Given this list of marker genes ECI2, UQCC5, PGM2L1, EXOC4, CS, TJP3 (tight junction protein 3), CXCL14, NIPAL3, SH3BGRL2, UBTD1, DDX3X, BAG6, KBTBD13, MICOS10, TBC1D15, CCDC22, APRT, CLUH, DENND4C, FLNA, SPEN-AS1, ATXN1, TRUB2, PIK3R2, ABHD12, TOMM6, CAMK1, IFI27, GTF2I, LGALS4, COL4A2, TGFBR1, MRPL20, CTNNB1, SH2B1, SERPINB6 (serpin family B member 6), GIT1, MT1E, HEBP1, ATP5MG (ATP synthase membrane subunit g), RALGDS, SSBP4, PABPC4, AGFG2 (NCBI Gene Id 3268), HADHA, DENND4B, MTURN, EEPD1, CCT3, DOCK5, SH3PXD2A, KLHL9, MGST1, GGA1, RAPH1, BOLA2, SPNS1, CAV1, PSEN2, SULT1A1, ST13, AGPAT5, ALDH16A1, LDHB, TMBIM1, IPO4, ITGB3, DDX19A, CNKSR3, MRPS6, PCDHGC4, RXRA, LRRC39, SDC1, AIFM2, NDUFA6, ZNF560, FAM209A, HBP1, PMM1, NDFIP1, SAMD4A, FCGRT, LRP1, NADK, MRPL23, SLC12A7, PEX5, STAB2, SOX7, GPCPD1, ITGAV, SLC11A1, MAN2B2, KDELR1, HSD17B4, MMGT1, FAM83F, SCARB2, MERTK, AGPAT1, MYO18A, ANO6, ANAPC13, ATP11C, ACBD5, PLIN2, MGLL, DMXL2, ADAM22, GLIS3, RAMP1, TRAPPC1, ACTN1, SKIC8, ENPP1, DAD1, RIT1, GPX4 (NCBI Gene Id 2879), GNA12, SLCO2B1, ZC3H3, ABCG1, CAT, GLRX5, RNF166 (NCBI Gene Id 115992), ALDH9A1, USP34, SNX9, PGLS (NCBI Gene Id 25796), TMEM208, OSGIN1, PRKAR2A, FBXL19, TPRA1, NPC1, CCNQ, TBCC, ICAM4, CD82, PRXL2A, TRAPPC10, SYK, HNMT, EEF2, SORD, SEPTIN9, GGA2, SPHK2, LAMTOR4, PLXDC2, BLVRB, DGLUCY, ABHD3, ATP13A3, SCAMP3, MFSD14A, HADHB, ZNF706, MRPS33, SELENOP, OAZ1, GCLM, PPT2, RAB29 (RAB29, member RAS oncogene family), ISCU, NEURL2, PDGFC, ARHGAP18, VAPA, ETFB, HVCN1, ANGPTL3, TMEM245 (NCBI Gene Id 23731), TAF1D, CLCN4, ECH1, ST18, SEPHS2, ZFAND2B, MAPRE1, CDK5R1, NME2, HNRNPL, KIF1C, NATD1, ACAA2, TKT, PNRC1, GNGT2, IMP3, HGSNAT, CD300A, TRAPPC6A, CCDC47, AFF4, ASPA, IQSEC1, SH3BGRL3, TBC1D2, here is a description of the gene set: IL-10 or IL-6 stimulation of control 129xC57BL/6 murine bone marrow derived macrophages in the presence of LPS. We used microarrays to detail the global programme of gene expression changes in response to IL-6 or IL-10 stimulation in the presence of lipopolysaccharide. BMDMs were isolated from control, IL-6-/-, and IL-10-/- mice on a 129XBL/6 mixed background mice and differentiated in the presence of CSF-1 for 6-7 days. Cells were scraped and plated in 6 well plates at 2x10e6/well. Cells were washed with complete DMEM and rested for 1-2 hr before stimulation with combinations of IL-10 (10 ng/ml), IL-6 (2 ng/ml) or LPS (100 ng/ml) for 45 min or 180 mins. Complete biological replicates were performed. Genes down-regulated in bone marrow-derived macrophages with IL6 knockout and 45 min of stimulation by AIL10 and LPS versus IL6 and LPS. species: Homo sapiens Human Gene Set: GSE5589_LPS_AND_IL10_VS_LPS_AND_IL6_STIM_IL6_KO_MACROPHAGE_45MIN_DN from publication El Kasmi KC, Holst J, Coffre M, Mielke L, de Pauw A, Lhocine N, Smith AM, Rutschman R, Kaushal D, Shen Y, Suda T, Donnelly RP, Myers MG Jr, Alexander W, Vignali DA, Watowich SS, Ernst M, Hilton DJ, Murray PJ (PMID 17114459)